The following is a description of a gene set: Genes up-regulated in comparison of macrophages versus neutrophils. In the present study we used Affymetrix oligonucleotide microarrays to produce gene transcription profiles for the major leukocyte types in humans. This comprehensive dataset enabled us to not only establish which genes were expressed in each leukocyte type, but also which genes were expressed in each subset after activation. The used of a comprehensive dataset of gene profiles from all the major human leukocyte subsets enabled a novel and powerful means for identification of genes associated with single leukocyte subsets, or different immune paradigms. Human Gene Set: GSE3982_MAC_VS_NEUTROPHIL_UP from publication Jeffrey KL, Brummer T, Rolph MS, Liu SM, Callejas NA, Grumont RJ, Gillieron C, Mackay F, Grey S, Camps M, Rommel C, Gerondakis SD, Mackay CR (PMID 16474395) studied in species Homo sapiens, and this is the list of marker genes: FAH, NUP155, TOP2A (DNA topoisomerase II alpha), ERAP1, ACYP1, JAG1, HSPE1, NOC2L, VWA8, PLA2G4A, GET3, PKM, MARCHF3, TOMM22, CCNA2, POLG, CSF1, VGLL4, MCCC2, G3BP2, ATP2A2, CBFB, HDAC2, CSRNP2, RAB9A (NCBI Gene Id 9367), RAN (NCBI Gene Id 87046), ZC3H14, SDAD1, CUL2, PEX2, OTUB2, ABRAXAS2, CRYZ, HYAL2, ETFB, TPP2, CENPM, UBR7, STOML2, FTO, MRPS22, SOCS5, TUBB3, BAG2, C1orf216, MYO6, TMEM168, MYO1D, STAM, RIOX2, CCL22, FBXO21, PTTG1, YTHDC2, DTWD1, SGPL1, SNRNP70, GTF3A, SOD1, EEF1E1, PPP2R3A, DOP1B, MTO1, DNASE2, ABCF1, PTK2 (NCBI Gene Id 5747), PPP1R7, PKD1P6, ZNF207, RGS10 (regulator of G protein signaling 10), MRPL12, RUVBL1, ADSL, ZCCHC14, CEP170, RTCA, TRIM44, NDUFA8, SPINT1, TIMM8B, NPRL3, PLGRKT, R3HDM1, MICU2, DNAAF5, C2CD2, PSMD1, FAM76A, PCNT, TACSTD2, NOP16, HINT1, SOX4, SPINT2, RPL8, UNC119B, TAF1D, PAAF1, NTHL1, GNA12, NEMF, SLC46A3, SUPV3L1, NEIL3, PKD1P1, RPN2, PRPF39, ARHGEF3, RNF185, MAP2K1, MRPL34, SNAPC2, IMPG1, FKBP3, TGDS, GNA11, DDO, P4HTM, CSE1L, HSD11B1, LRRC47, ZNF629, MATN3, PAN2, YBX3, COQ4, FAM114A2, AGA, RITA1, TBC1D2B, ILRUN, PLA2G4C, INTS5, MEAK7, DDOST, SLC20A1 (solute carrier family 20 member 1), AAMP, ABCC10, GTF2F2, P4HA2 (NCBI Gene Id 8974), PRKAA2, PAPSS1, NME7, ENG, PRPF4, MMP2, AP2B1, NDUFC2, CXCL5, LUZP1, CRB1, CTSV, IRS1, FGF9, AHCYL1, RSL24D1, QPRT, PEX14, FUCA1, CPT2, DNAJC28, CKAP2, LPIN1, HDHD5 (haloacid dehalogenase like hydrolase domain containing 5), TRAPPC3, CSRP1, ADI1, RARS1, PTMS, CD68, MRPL58, NFE2L3, ZNF184, MMACHC, UPF3A, MAPK9 (NCBI Gene Id 5601), ALDH18A1, STUB1, HMGB3, ERO1A, ITFG1, RRM1, FOLR2, SPSB1, ABCC3, ODR4, PCBP4, APOO, ADAM10, PHF10, PCMT1, AIMP2, ADA, PFDN4, XBP1, BZW1, AGGF1, DIXDC1